The following is a description of a gene set: A filament of myosin found in a muscle cell of any type. Human Gene Set: GOCC_MUSCLE_MYOSIN_COMPLEX studied in species Homo sapiens, and this is the list of marker genes: MYL11, MYH2, MYH7, MYH6, MYL6B, MYL1, MYL5, MYL3, MYL9, MYH11, MYH1, MYH4, MYH3, MYH8 (myosin heavy chain 8), MYH13